The following is a description of a gene set: Human Gene Set: KIM_LIVER_CANCER_POOR_SURVIVAL_UP Genes over-expressed in hepatocellular carcinoma (HCC) with poor survival studied in species Homo sapiens In approximately 70% of patients with hepatocellular carcinoma (HCC) treated by resection or ablation, disease recurs within 5 years. Although gene expression signatures have been associated with outcome, there is no method to predict recurrence based on combined clinical, pathology, and genomic data (from tumor and cirrhotic tissue). We evaluated gene expression signatures associated with outcome in a large cohort of patients with early stage (Barcelona-Clinic Liver Cancer 0/A), single-nodule HCC and heterogeneity of signatures within tumor tissues. from publication Villanueva A, Hoshida Y, Battiston C, Tovar V, Sia D, Alsinet C, Cornella H, Liberzon A, Kobayashi M, Kumada H, Thung SN, Bruix J, Newell P, April C, Fan JB, Roayaie S, Mazzaferro V, Schwartz ME, Llovet JM (PMID 21320499), and this is the list of marker genes: SPHK1, ALDOA, PPT1, TSPAN3, CXCR4, PKM, TM4SF1, JPT1, RGS2, PLOD2, CTSC, IQGAP1, DDIT4, LAMB1, SLC38A1, ETV5, IGFBP3 (insulin like growth factor binding protein 3), RALA, F3, RGS1, PFKFB3, ARPC2